Given this list of marker genes PTH, ATP2B1, BMP4, BMP7, CCN1, SLC8A1, ALOX5, AMTN, BMPR1A, ADRB2, GPM6B, KL, BMP2, PKDCC, FBN2, PTN, BMP6, BMPR2, ACVR2B, ACVR1, CFTR, TFAP2A, SLC20A2, P2RX7, TENT5A, ENAM, FBXO5, WNT4, ACTN3, TMEM119, ISG15, ANO6, OSR1, AMELX, OSR2, RXRA, ODAPH, VDR, ATF4, ACVR2A, CEBPB, MEF2C, SLC4A2, ATRAID, LTF, RXRB, FAM20C, WNT6, ADGRV1, NELL1, WNT10B, SMAD3, BMPR1B, FZD9, here is a description of the gene set: Any process that activates or increases the frequency, rate or extent of biomineral tissue development, the formation of hard tissues that consist mainly of inorganic compounds. species: Homo sapiens Human Gene Set: GOBP_POSITIVE_REGULATION_OF_BIOMINERAL_TISSUE_DEVELOPMENT